Given this list of marker genes SEMA4A, BMPR1A, TNPO3, ATM, POLD1, POLE, CHEK2, BRCA2, SLC6A8, MUTYH (mutY DNA glycosylase), RPS20, here is a description of the gene set: studied in species Homo sapiens Human Gene Set: HP_ABNORMAL_CIRCULATING_CREATINE_CONCENTRATION Abnormal circulating creatine concentration A deviation from the normal concentration of creatine in the blood circulation. Creatine is a derivative of glycine having methyl and amidino groups attached to the nitrogen. Creatine is naturally produced from amino acids, primarily in liver and kidney, and acts as an energy source for cells, primarily for muscle cells.